The following is a description of a gene set: Genes predicted to be targets of miRBase v22 microRNA mmu_miR_138_5p in miRDB v6.0 with MirTarget v4 prediction scores > 80 (high confidence targets). species: Mus musculus from publication Chen Y, Wang X (PMID 31504780) Mouse Gene Set: MIR_138_5P, and this is the list of marker genes: Zfp36l2, Tab3, Arrb1, Sptb, Lin52, Arglu1, Eid1, Kif26a, Lamc1, Cstdc2, Slc6a8, Ndst2, Psd2, Oxtr, Senp1, 5031439G07Rik, Reln, Pard3, Fabp9, Mlxip, Tmem198, D17H6S53E, Dtx4, Nnat, Col3a1, Sys1, Afap1, Daam2, Chd6, Rp1, Tram1, Desi2, Ttc28, Zer1, Vezf1, Als2cl, Map6, Mcu, Klf11, Baz1b, Pvr, 1700017B05Rik, Zfp385a, Mxd1, Zfp148, Mbtps2, Arl6ip5, Ptpn4, Smap2, Ildr2, Atcay, Rara, Tet2, Ing1, Mllt6, Tmtc4, Psd, Foxp4, Senp5, Sirt1, Fmo2, Epha8, Sh3gl2, Hnf1b, Nkapd1, Lsm14a, Rfwd3, Dot1l, Arhgef3, Eri1, Clvs1, Nfix, Caln1, Med26, Zfat, Sez6l2, Lypla1, Rasl12, Has3, Rmnd5a, Tulp4, Bcl11a, Mb21d2, Rela, Rims2, Tiparp, Ankrd54 (NCBI Gene Id 27619), Ezh2 (enhancer of zeste 2 polycomb repressive complex 2 subunit), Dek, Tmod2, Dcp1a, Slc17a7, Arhgap32, Sfswap, Neurod1, Sertad4, Pdik1l, Gypc, Nppc, Kbtbd4, Celf5, Kmt5b, Corin, Peg10, Clns1a, Prpf40a, Arhgap6, Rcan2, Ank1, Hbegf, Yipf5, Fyco1, Gng2, Oaf, Mtf2, Plxnb2, Dvl2, Pappa, Pros1, Sorbs2, Atp11c, Cnot8, Slx4, Hs1bp3, Lzts3, Nsmf, Sin3a, Syn3, Jmjd8, Foxc1, Amotl2, Trps1, Cped1, Igf2bp2, Cldn2, Pxmp4, Nbea, Bltp3a, Cnot9, Ptk2, Arhgap42, Slc6a17 (NCBI Gene Id 99905), Scn8a, Zeb2, Pde7b, Ftcd, Ago1, Unc5a, Slco3a1, Usp10, Nfib, Pxk (PX domain containing serine/threonine kinase), Kdm5c, Lman1, Ptpn2, Usp47, Kmt2c, Thrb, St6galnac4, Fermt2, Ppargc1a, Cnot6l, Upf2, Sh2b3, Mtus2, Arrdc3, L3mbtl3 (NCBI Gene Id 237339), Clock, Jazf1, Fbln5 (fibulin 5), Thap11, Rock2, Clec1a (C-type lectin domain family 1, member a), Mbnl3, Hoxb9, Fem1c, Mief2, Tmub2